The following is a description of a gene set: species: Mus musculus Catalysis of the hydrolysis of ester linkages within ribonucleic acids by creating internal breaks to yield 3'-phosphomonoesters. Mouse Gene Set: GOMF_RNA_ENDONUCLEASE_ACTIVITY_PRODUCING_3_PHOSPHOMONOESTERS, and this is the list of marker genes: Tsen34, Ear14, Rnaset2b, Rnase1, Rnase2b, Tsen2, Rnaset2a, Rida